Given this list of marker genes Magi2, Shank1, Dlg1, Dlg2, Dlgap1, Dlg3, Rapsn, Dlg4, Shank2, Git1, Shank3, Mpp2, Ctnnd2, here is a description of the gene set: studied in species Mus musculus Mouse Gene Set: GOMF_STRUCTURAL_CONSTITUENT_OF_POSTSYNAPTIC_SPECIALIZATION The action of a molecule that contributes to the structural integrity of a postsynaptic specialization.